The following is a description of a gene set: A structural anomaly of the substantia nigra, which is a midbrain dopaminergic nucleus which has a critical role in modulating motor movement and reward functions as part of the basal ganglia circuitry. species: Homo sapiens Human Gene Set: HP_ABNORMAL_SUBSTANTIA_NIGRA_MORPHOLOGY Abnormal substantia nigra morphology, and this is the list of marker genes: SNCAIP, FTL, TBCE, VPS41, LRRK2, TBP, GTPBP2, ATXN2, SLC44A1, GBA1, PRKN, MT-TT, FBXO7, SPG11, WDR45, IMPDH2, ADH1C, GCH1 (NCBI Gene Id 93984), NR4A2, MAPT, SNCA, ATXN3, ATXN8OS (ATXN8 opposite strand lncRNA)